The following is a description of a gene set: The process in which epiblast cells acquire specialized features of neuroepithelial cells. studied in species Homo sapiens Human Gene Set: GOBP_NEUROEPITHELIAL_CELL_DIFFERENTIATION, and this is the list of marker genes: MAP1B, B9D1, SOX11, IFT80, ASCL1, GATA2, HES1, FGF8, NKX2-2, BMP4, WNT4, BCCIP (NCBI Gene Id 56647), DLX3, FGF2, LHX3, RPTOR, OTP, NOTCH1 (NCBI Gene Id 54781), DLL1, TMEM231, DSPP, INSM1, TGFB1, RFX6 (regulatory factor X6), SERPINE1, SOX4, IPO7, ABL1, CDH2, POU3F2, BMP2, ONECUT1, LEF1, NODAL, TUBB, NFE2L1, NKX6-3, DLG5, MSX1 (NCBI Gene Id 4487), WNT11 (NCBI Gene Id 7481), CEBPB, VAX1, EMX1, JAG1, CTNNB1, FAM20C, SMAD2